Given this list of marker genes CXCR6 (NCBI Gene Id 10663), PDLIM1, GZMK, KRT86, TOX2, here is a description of the gene set: from publication He P, Lim K, Sun D, Pett JP, Jeng Q, Polanski K, Dong Z, Bolt L, Richardson L, Mamanova L, Dabrowska M, Wilbrey-Clark A, Madissoon E, Tuong ZK, Dann E, Suo C, Goh I, Yoshida M, Nikolić MZ, Janes SM, He X, Barker RA, Teichmann SA, Marioni JC, Meyer KB, Rawlins EL (PMID 36493756) Human Gene Set: HE_LIM_SUN_FETAL_LUNG_C4_CD56BRIGHT_NK_CELL studied in species Homo sapiens CD56bright NK